Given this list of marker genes DRD5, AVPR2, OXTR, AVPR1A, AVPR1B, here is a description of the gene set: species: Homo sapiens Human Gene Set: GOBP_REGULATION_OF_SYSTEMIC_ARTERIAL_BLOOD_PRESSURE_BY_VASOPRESSIN The regulation of blood pressure mediated by the signaling molecule vasopressin. Vasopressin is produced in the hypothalamus, and affects vasoconstriction, and renal water transport.